The following is a description of a gene set: studied in species Homo sapiens Any process that stops, prevents or reduces the frequency, rate or extent of guanyl-nucleotide exchange factor activity. Human Gene Set: GOBP_NEGATIVE_REGULATION_OF_GUANYL_NUCLEOTIDE_EXCHANGE_FACTOR_ACTIVITY, and this is the list of marker genes: STMN1, GPSM1, MET, RIPOR2, RIPOR1